Given this list of marker genes KANSL1, SLC2A10, MEG3, FAT4, ATP6V1E1, NCF4, NIPBL, PLEC, GTF2H5, GABRD, PEX26, PEX11B, KCNAB2, PEX19, ARF1, FBLN5, PEX13, NAA10, SMC1A, UBE4B, HSPG2, GALE, TBX3, LUZP1, SH2B1, MTMR14, LAMB3, SERPINH1, ZNF699, MMP23B, HRAS, NPHS1, CYBB, DLK1, PEX2, ZFX, PEX14, VAC14, TFAP2A, SYT2, LTBP4, DNM2, DHCR7, DYRK1A, NEDD4L, BIN1, CYBC1, NEK9, BCOR, ITGB4, LTBP1, COL18A1, BCR, MTM1, PAK2, ZEB2, MYF6, ERMARD, NCF2, TMTC3, PEX1, PRKCZ, CRKL, ADAMTS3, PDPN, SPEN, RAD21, FGFR2, CHD8, RYR1, PPP2R5D, PRDM16, NFKB2, PEX6, SMC3, RTL1 (NCBI Gene Id 651665), PEX16, PYCR1, BRD4, CAVIN1, HDAC4, DHODH, PPP2R3C, LAMA3, PEX5, SKI, TAF6, NCF1, ARFGEF2, FLNA, MED12, FLI1, CCBE1, NFIX, HNF1B, EFEMP2, PIEZO2, CASZ1, CYBA, MAPK1, PEX10, NEFH, FIG4, MAP1B, RERE, PEX12, HDAC8, ITGA6, PEX3, LAMC2, MAP3K7, here is a description of the gene set: species: Homo sapiens Abnormality of the pylorus An abnormality of the pylorus. Human Gene Set: HP_ABNORMALITY_OF_THE_PYLORUS